The following is a description of a gene set: The chemical reactions and pathways involving malate, the anion of hydroxybutanedioic acid, a chiral hydroxydicarboxylic acid. The (+) enantiomer is an important intermediate in metabolism as a component of both the TCA cycle and the glyoxylate cycle. species: Mus musculus Mouse Gene Set: GOBP_MALATE_METABOLIC_PROCESS, and this is the list of marker genes: Mdh2, Lipf, Mdh1b, Me2, D2hgdh, Mdh1, Fh1, Me3 (NCBI Gene Id 77456), Me1